The following is a description of a gene set: Reactome Pathway: Biosynthesis of A2E, implicated in retinal degradation Lipofuscin is a yellow-brown pigment grain composed mainly of lipids but also sugars and certain metals. Accumulation of lipofuscin is associated with degenerative diseases such as Alzheimer's disease, Parkinson's disease, chronic obstructive pulmonary disease and retinal macular degeneration.<br><br>A prominent component of lipofuscin in retinal pigment epithelial (RPE) cells is the bisretinoid A2E (di-retinoid-pyridinium-ethanolamine), the end-product of the condensation of 2 molecules of all-trans-retinal (atRAL) and phosphatidylethanolamine (PE) in photoreceptor outer disc membranes. Once formed, A2E is phagocytosed, together with outer segments (Kevany & Palczewski 2010), to RPE where it accumulates. There is no evidence as yet to indicate that A2E can be catabolised. A simplified biosynthetic pathway for A2E is described here. species: Homo sapiens part of: Retinoid cycle disease events, and this is the list of marker genes: NAPEPLD